Given this list of marker genes CDK1, JAK2, IL6, MAPK3, IL6ST, PTPN11, IL6R, MAP2K1, TYK2, JAK1, here is a description of the gene set: Human Gene Set: REACTOME_MAPK3_ERK1_ACTIVATION MAPK3 (ERK1) activation species: Homo sapiens